Given this list of marker genes ATM, KDM1A, EEF1E1, KMT5A, PLA2R1, PSMD10, ING4, NPM1, SPRED2, DDX5, SMYD2, ANKRD1, ZNF385A, CD74, SIRT1, CDKN2A, MARCHF7, DYRK1A, RPL26, MIF, ZNHIT1, ATR, TP53, SOX4, PMAIP1, YJU2, SNAI2, SNAI1, CD44, MDM2 (NCBI Gene Id 84825), DYRK3, COPS3, SPRED1, ZMPSTE24, PTTG1IP, TWIST1, PYHIN1, MSX1 (NCBI Gene Id 4487), HIC1 (NCBI Gene Id 3090), here is a description of the gene set: Any process that modulates the frequency, rate or extent of the cascade of processes induced by the cell cycle regulator phosphoprotein p53, or an equivalent protein, in response to the detection of DNA damage. studied in species Homo sapiens Human Gene Set: GOBP_REGULATION_OF_DNA_DAMAGE_RESPONSE_SIGNAL_TRANSDUCTION_BY_P53_CLASS_MEDIATOR